Given this list of marker genes PSMB5, PSMC2, PSMA5, PSMA3, PSMA2, PSMA7, PSMD11, PSMC3, PSMB7, PSMC6, PSMC5, PSMD6, PSMD4, SEM1, PSMD9, HTT, PSMD1, PSMB2, PSMA8, ADRM1, PSMD12, PSMD8, PSMB3, PSMC1, PSMD7, PSMD14, PSMB4, PSMA4, PSMA6, PSMC4, PSMD2, PSMA1, PSMB6, PSMD3, PSMB1, PSMD13, here is a description of the gene set: studied in species Homo sapiens Human Gene Set: KEGG_MEDICUS_VARIANT_MUTATION_CAUSED_ABERRANT_HTT_TO_26S_PROTEASOME_MEDIATED_PROTEIN_DEGRADATION Pathway Definition from KEGG: HTT* -| 26S Mutation-caused aberrant Htt to 26S proteasome-mediated protein degradation. Pathway ID: N01061. Pathway type: Variant. Pathway class: nt06461 Huntington disease.